The following is a description of a gene set: species: Homo sapiens Human Gene Set: GOBP_POSITIVE_REGULATION_OF_NUCLEOTIDE_CATABOLIC_PROCESS Any process that activates or increases the frequency, rate or extent of the chemical reactions and pathways resulting in the breakdown of nucleotides., and this is the list of marker genes: UCHL1, GPD1, GAPDHS, IGF1, RPTOR, PRKAA2, ZBTB20, HIF1A, SLC4A4, PSEN1, HTR2A, SRC (NCBI Gene Id 6714), PRKAA1, INSR, MLST8, MTOR, INS, MLXIPL, PRXL2C, APP, ARNT, IFNG (interferon gamma), KAT2B, P2RX7